The following is a description of a gene set: electronically inferred by orthology from the curated human pathway part of: Regulated Necrosis This event has been computationally inferred from an event that has been demonstrated in another species.<p>The inference is based on the homology mapping from PANTHER. Briefly, reactions for which all involved PhysicalEntities (in input, output and catalyst) have a mapped orthologue/paralogue (for complexes at least 75% of components must have a mapping) are inferred to the other species. Reactome Pathway: RIPK1-mediated regulated necrosis species: Mus musculus, and this is the list of marker genes: Flot2, Fasl, Birc3, Fadd (NCBI Gene Id 14082), Prkn, Ubb, Casp8, Flot1, Mlkl, Fas, Rps27a, Tradd, Cdc37, Sdcbp